Given this list of marker genes Nostrin, Cav1, Dnm2, here is a description of the gene set: species: Mus musculus part of: Metabolism of nitric oxide: NOS3 activation and regulation This event has been computationally inferred from an event that has been demonstrated in another species.<p>The inference is based on the homology mapping from PANTHER. Briefly, reactions for which all involved PhysicalEntities (in input, output and catalyst) have a mapped orthologue/paralogue (for complexes at least 75% of components must have a mapping) are inferred to the other species. Reactome Pathway: NOSTRIN mediated eNOS trafficking electronically inferred by orthology from the curated human pathway